Given this list of marker genes Psma2, Psma6, Psma7, Psmd12, Psmc3, Psmc6, Psmb4, Psmd1, Psma5, Dvl3, Dvl2 (dishevelled segment polarity protein 2), Psmb5, Psmc5, Psmd7, Hecw1, Psma4, Psmb7, Psmb6, Psmd6, Psmc4, Psmd13, Psma1, Psmc2, Rps27a, Psmc1, Psma3, Klhl12, Dvl1, Ubb, here is a description of the gene set: electronically inferred by orthology from the curated human pathway This event has been computationally inferred from an event that has been demonstrated in another species.<p>The inference is based on the homology mapping from PANTHER. Briefly, reactions for which all involved PhysicalEntities (in input, output and catalyst) have a mapped orthologue/paralogue (for complexes at least 75% of components must have a mapping) are inferred to the other species. part of: TCF dependent signaling in response to WNT Reactome Pathway: Degradation of DVL species: Mus musculus